Given this list of marker genes Hsp90aa1, Ptges3 (NCBI Gene Id 80424), Hsp90ab1, Hsf1, Ywhae, Vcp, Hdac6, Eef1a1, here is a description of the gene set: Mouse Gene Set: REACTOME_HSF1_ACTIVATION HSF1 activation studied in species Mus musculus